Given this list of marker genes GNB1, GNG8, CXCL8, GNG10, GNG11, GNG5, GNB2, MAP2K2, HRAS, NRAS, RAF1, GNG2, MAPK3 (mitogen-activated protein kinase 3), CXCR2, MAP2K1, GNG7, GNG12, GNG13, KRAS, GNB3 (G protein subunit beta 3), GNB5, MAPK1, GNGT2, GNG3, GNG4, GNB4, GNGT1, here is a description of the gene set: Pathway Definition from KEGG: CXCL8 -> CXCR2 -> GNB/G -> RAS -> RAF1 -> MEK -> ERK CXCR-GNB/G-ERK signaling pathway. Pathway ID: N00152. Pathway type: Reference. Pathway class: nt06224 CXCR signaling. species: Homo sapiens Human Gene Set: KEGG_MEDICUS_REFERENCE_CXCR_GNB_G_ERK_SIGNALING_PATHWAY